Given this list of marker genes U2AF1, ZC3H8, ANKS1B, NOP10, USH1G, SMNDC1, SCARNA1, DKC1, SCARNA11, WRAP53, XPO1, SCARNA21, ANGEL2, TRIM22, SCARNA14, SRRM2, UBL5, ICE2, HNRNPA2B1, NHP2, NOP58, HABP4, ZPR1, SCARNA23 (NCBI Gene Id 677773), VRK1, ARIH1, COIL, ZNF473, ICE1, PRPF3, NPAT, NOLC1, SCARNA15, SCARNA22, SCARNA3, ISG20, USPL1, OIP5, HMBOX1, PRPF4, FAM118B, SCARNA5, SCARNA8, HINFP, SCARNA4, SART3, DDX42, SMN2, EWSR1, TGS1, CDK2, SNHG10, SNORA38, DDX46, SCARNA10, LSM10, SNORA38B, TERC (NCBI Gene Id 7012), SCARNA13, PRPF31, SHQ1, HSPB7, SMN1, SCARNA17, EAF1, SCARNA21B, FMR1, FRG1, SCARNA20, PHAX, SNRPC, FBLL1, ELL, GAR1, AK6, GARIN3, LSG1, TOE1, EFTUD2, SART1, GEMIN4, FBL, RDM1, here is a description of the gene set: species: Homo sapiens Human Gene Set: GOCC_CAJAL_BODY A class of nuclear body, first seen after silver staining by Ramon y Cajal in 1903, enriched in small nuclear ribonucleoproteins, and certain general RNA polymerase II transcription factors; ultrastructurally, they appear as a tangle of coiled, electron-dense threads roughly 0.5 micrometers in diameter; involved in aspects of snRNP biogenesis; the protein coilin serves as a marker for Cajal bodies. Some argue that Cajal bodies are the sites for preassembly of transcriptosomes, unitary particles involved in transcription and processing of RNA.